Given this list of marker genes CCDC18-AS1 (NCBI Gene Id 100131564), PARD6A (NCBI Gene Id 50855), CUEDC2, ARF3, AMZ2P1, SNHG15, ST6GALNAC6, DR1, RAN (NCBI Gene Id 87046), PPIA, ACD (NCBI Gene Id 82538), here is a description of the gene set: species: Homo sapiens from publication Yevshin I, Sharipov R, Kolmykov S, Kondrakhin Y, Kolpakov F (PMID 30445619) Genes containing one or more binding sites for (STN1) in their promoter regions (TSS -1000,+100 bp) as identified by GTRD version 20.06 ChIP-seq harmonization. Human Gene Set: STN1_TARGET_GENES